Given this list of marker genes AKT2, 3a, PDPK1, YWHAZ (NCBI Gene Id 83242), SFN, M, CAV1, YWHAG, YWHAB, YWHAE, YWHAH, AKT1, YWHAQ, N, AKT3, here is a description of the gene set: studied in species Homo sapiens part of: SARS-CoV-2-host interactions Reactome Pathway: SARS-CoV-2 targets host intracellular signalling and regulatory pathways Severe acute respiratory syndrome coronavirus type 2 (SARS‑CoV‑2) encodes several proteins that modulate host intracellular signaling and regulatory pathways. Among them are membrane M, nucleocapsid N and 3a proteins that directly bind to host targets associated with SARS‑CoV‑2 infection and cytokine production. First, SARS‑CoV‑2 M binds to 3‑phosphoinositide‑dependent protein kinase 1 (PDPK1) to inhibit PKB/Akt activation (Ren Y et al. 2021). Second, SARS‑CoV‑1 N binds to the host 14-3-3 protein, which regulates nucleocytoplasmic shuttling and other functions of N (Tugaeva KV et al. 2021). Third, binding of viral 3a to the regulator and scaffolding protein caveolin‑1 (CAV1) may regulate virus uptake as well as the trafficking of viral structural proteins (inferred from the orthologous protein in SARS-CoV-1).